The following is a description of a gene set: Reactome Pathway: PI3K Cascade studied in species Homo sapiens part of: IRS-mediated signalling The PI3K (Phosphatidlyinositol-3-kinase) - AKT signaling pathway stimulates cell growth and survival., and this is the list of marker genes: FLT3LG, FGFR4, FGF17 (NCBI Gene Id 8822), FGF23, FGF16, FGF8, FGF1, PTPN11, FGFR2, AKT2, THEM4, FGFR1 (fibroblast growth factor receptor 1), FGF5, PDPK1, PIK3R1, FLT3, IRS1, FGF4, FGF20, PIK3CA, FGF2, TLR9, FGF10, FGF9, FGF22, KL, IRS2, PIK3CB, FGF7, FGF19, PIK3R4, GAB2, GAB1, FGF18, GRB2, FRS2, TRIB3, PIK3C3, FGF6, FGFR3, PIK3R2, PDE3B, FGF3, KLB